Given this list of marker genes Iqgap1, Foxj1, Nphs2, Ampd2, Asxl1, Notch2, Myo1e, Podxl, Magi2, Nphs1, Lamb2, Adipoq, Wt1, Jag1, here is a description of the gene set: The process whose specific outcome is the progression of a glomerular epithelial cell over time, from its formation to the mature structure. Glomerular epithelial cells are specialized epithelial cells that form part of the glomerulus; there are two types, glomerular parietal epithelial cells and glomerular visceral epithelial cells. Mouse Gene Set: GOBP_GLOMERULAR_EPITHELIAL_CELL_DEVELOPMENT studied in species Mus musculus